Given this list of marker genes Acta1, Actn3, Ppp3ca, Myod1, Cflar, Myh7, Mstn, Ar, Gtf2ird1, Tnnt1, Nfatc1, Myoz1, Myoc, Tnnc1, Cmya5, Tnni1, Mymk, Tead1, Myoz2, Gtf2ird2, Mtor, Igfbp5, Asb2, Rps6kb1, Cacna1s, Atp2a2, here is a description of the gene set: Any process in which skeletal muscles change their phenotypic profiles in response to altered functional demands and a variety of signals. species: Mus musculus Mouse Gene Set: GOBP_SKELETAL_MUSCLE_ADAPTATION